The following is a description of a gene set: Pol III initiation complexes open the promoter spontaneously similar to the mechanism employed in archaeal and bacterial transcription. Reactome Pathway: RNA Polymerase III Chain Elongation species: Homo sapiens part of: RNA Polymerase III Transcription, and this is the list of marker genes: POLR3A, POLR2E, POLR2L, POLR2F, POLR3E, POLR2K, POLR3D, POLR3F, POLR3K, POLR3B, POLR3H, POLR3G, CRCP, POLR2H, POLR1C, POLR3GL, POLR1D, POLR3C